Given this list of marker genes TNRC6A, MIR429, AGO4, MIR93, MIR34C, TNRC6B, MIR34B (microRNA 34b), MIR152, MIR142, TNRC6C, MIR200B, CD274, MOV10, MIR138-1, MIR200C, MIR340, AGO1, MIR140, MIR148A, MIRLET7A1, AGO3, MIR34A, MIR424, AGO2, here is a description of the gene set: Reactome Pathway: Regulation of PD-L1(CD274) translation species: Homo sapiens part of: Regulation of PD-L1(CD274) expression The synthesis of PD-L1 (CD274) protein from its mRNA under various physiological and pathological conditions is tightly regulated by microRNAs (miRNAs) that bind to the 3' untranslated region (3' UTR) of PD-L1 mRNA, influencing its stability and translation efficiency. For example, miR 34a and miR 200 directly target PD L1 mRNA, leading to decreased protein synthesis, which is important in controlling autoimmune response in normal physiological conditions and immune escape mechanisms in cancer. The translation regulation of PD-L1 is a critical area of research, particularly in the context of cancer and other diseases where PD-L1 is implicated in pathology.